Given this list of marker genes Capzb, Baiap2l2 (BAI1-associated protein 2-like 2), Rab7, Fam169a, Esyt1, Diaph3, Srgap2, Senp1, Cav1, Vamp3, Slc4a7, Farp1, Actn1, Depdc1b, Vangl1, Arhgap5, Baiap2l1 (NCBI Gene Id 66898), Myo9b, Add3, Actg1, Arhgap39, Pik3r1, Snap23, Arhgap1, Diaph2, Lmnb1, Diaph1, Arhgap21, Actb, Tor1aip1, Rhof, Akap12, Mcam, Basp1, Arhgap12, Arhgap32, Pik3r2, Mtmr1, Syde1, Sowahc, Steap3, here is a description of the gene set: studied in species Mus musculus RHOF GTPase cycle Mouse Gene Set: REACTOME_RHOF_GTPASE_CYCLE